The following is a description of a gene set: studied in species Homo sapiens Catalysis of the reaction: inositol phosphate(n) + H2O = inositol phosphate(n-1) + phosphate. This reaction is the removal of a phosphate group from an inositol phosphate. Human Gene Set: GOMF_INOSITOL_PHOSPHATE_PHOSPHATASE_ACTIVITY, and this is the list of marker genes: BPNT1, MTMR7, INPP5A, INPP5D, INPP1, OCRL, SYNJ1, IMPA2, INPP5B, INPP5F, INPP4B, INPPL1 (inositol polyphosphate phosphatase like 1), PTEN, INPP4A, MINPP1, IMPA1, INPP5E, SYNJ2, INPP5K, INPP5J